The following is a description of a gene set: species: Homo sapiens Cranial nerve compression Human Gene Set: HP_CRANIAL_NERVE_COMPRESSION, and this is the list of marker genes: SH3TC2, CDH23 (cadherin related 23), CDKN1A, CLCN7, TP53, SCN1A, ATRX, VCP, PRRT2, EPAS1, PLEKHM1, SDHA, RET, USP48, MDH2, DKK1, NF1, TMEM127, VHL, LRP4 (NCBI Gene Id 4038), FH, TGFB1, CDKN1B, SDHAF2, HNRNPA1, SNX10, COL4A1, CA2, MAX, KIF1B, SDHD, DLST, TCIRG1, HNRNPA2B1, TMEM53, ATP1A2, USP8, NFU1, TNFRSF11A, MTRFR, CDKN2C, SDHC, MEN1, BRAF, SDHB, CDKN2B, TNFSF11, CACNA1A, SLC25A11, DNMT3A, NR3C1